Given this list of marker genes HACE1, SERPINF2, RUNX1 (RUNX family transcription factor 1), CYP2R1 (NCBI Gene Id 79445), TGFB1, HABP2, VCP, RARA, DKK1, NUMA1, IDH2, SRSF2, TBL1XR1, NABP1, GATM, STAT5B, ENPP1, TREM2, IDH1, PSMB8, FIP1L1, TYROBP, LIN28B, TET2, PSAP, PRKAR1A, MYCN, STAT3, EXT1, KIT, FGF23, RAD21, PHOX2B, EHHADH, GBA1, CLCN5, WNT1, BCOR (BCL6 corepressor), CYP27B1, SNX10, ZBTB16, NOTCH2 (NCBI Gene Id 55574), IL1R1, NPM1, ELANE, WNT3A, PHEX, PTH1R, GNAS, MINPP1, VDR, LPIN2, BRAF, SLC34A3, ZNF687, LEMD3, SLC34A1, GNPTAB, SLCO2A1, TNFRSF11A, ATP7B, PTPN11, BMP4, MAP2K1, TNFRSF1A, ASXL1, CYP19A1 (cytochrome P450 family 19 subfamily A member 1), FOXE1, POLE, TRPS1, SCARB2, LMO1, TEK, CBL, ALK, DMP1, AP2S1, CCND1, TNFSF11, CDC73, AGXT (alanine--glyoxylate aminotransferase), TCIRG1, IRF2BP2, HPGD, PML, CLCN7, SQSTM1, NDUFAF6, NRAS (NCBI Gene Id 4893), KIF1B, here is a description of the gene set: Human Gene Set: HP_BONE_PAIN Bone pain An unpleasant sensation characterized by physical discomfort (such as pricking, throbbing, or aching) localized to bone. studied in species Homo sapiens